Given this list of marker genes SPCS2, P2RX7, PDE5A, ARFGEF1, UBE2H, CHST9, YBX1, EIF4G3, NSRP1, AMOTL2, MBNL2, HSPA2, LHX8, RPE, HPS4, SGK1, ZNF280C, KMT5A, CILK1, SEC24C, TOP1, PPP3CC, AQP6 (aquaporin 6), SMARCAD1, VEZF1, ZCCHC14, HS3ST3B1, BACH1, STC1, EDA, BDNF, MTUS1, EN2, ATP2B1, CAMTA1, GMFB, MMP16, ARID1B, ARIH2, SRGAP2, PDPK1, BCL11B, SYT1, LIN9, SYNC, EEF1A1, MATR3, BCORL1, AKIRIN1, PLPPR2, MIEF1, HSPA14, PRPS2, NFIA, DDX3Y, CLTC, SORCS3, BTBD7, VEZT, ACVR1, DDX3X, MFSD14B, MBNL1, ZNF106, DCAF10, DACH1, EPC2, COLQ, NDRG2, NEGR1, DHX15, SLC17A6, here is a description of the gene set: Genes having at least one occurence of the motif ACAACTT in their 3' untranslated region. The motif represents putative target (that is, seed match) of human mature miRNA hsa-miR-382 (v7.1 miRBase). studied in species Homo sapiens Human Gene Set: ACAACTT_MIR382